The following is a description of a gene set: from publication Wei G, Wei L, Zhu J, Zang C, Hu-Li J, Yao Z, Cui K, Kanno Y, Roh TY, Watford WT, Schones DE, Peng W, Sun HW, Paul WE, O'Shea JJ, Zhao K (PMID 19144320) Multipotential naïve CD4+ T cells differentiate into distinct lineages including T helper 1 (Th1), Th2, Th17, and inducible T regulatory (iTreg) cells. The remarkable diversity of CD4+ T cells begs the question whether the observed changes reflect terminal differentiation with heritable epigenetic modifications or plasticity in T cell responses. We generated genome-wide histone H3 lysine 4 (H3K4) and lysine 27 (H3K27) trimethylation maps in naïve, Th1, Th2, Th17, iTreg, and natural (n)Treg cells. We found that although modifications of signature cytokine genes (Ifng, Il4, and Il17) partially conform to the expectation of lineage commitment, critical transcription factors such as Tbx21 exhibit a broad spectrum of epigenetic states, consistent with our demonstration of T-bet and IFN-gamma induction in nTreg cells. Our data suggest an epigenetic mechanism underlying the specificity and plasticity of effector and regulatory T cells and also provide a framework for understanding complexity of CD4+ T helper cell differentiation. species: Homo sapiens Genes up-regulated in comparison of Th2cells versus induced regulatory T cell (Treg). Human Gene Set: GSE14308_TH2_VS_INDUCED_TREG_UP, and this is the list of marker genes: PRSS22, MAGI2, KLF10, GTSF1, IDS, GKAP1, ACAP3 (NCBI Gene Id 80855), SLC36A1, IFT27, BCAR3, TPP1, ARPC1A, TAF13 (TATA-box binding protein associated factor 13), PDLIM2, CDKL2, DARS1, RTL8B, PURA, ZCCHC13, PANK2, RPS26, MTPN, DGUOK, ECI2, RGS11, OSBPL3, B2M, IRS2, CLK4, MSI2, INPPL1, ARAP3, GALNT18, ARPC2, MKRN1, EIF5, KATNBL1 (katanin regulatory subunit B1 like 1), CEP250, AIP, LEPROTL1, DKKL1, GMPPA, MFSD8, AGA (NCBI Gene Id 175), LRP6, VILL, PHLDA3, ORC4, TBPL1, FKBP8, PHF1, RELCH, STAP1, NAB1, MYH11, TIA1, OLA1, FAM13B, YME1L1, BET1, ZC2HC1A, GYG1, GPRIN3, PRMT9, KIZ (NCBI Gene Id 57166), SPMAP1, HCN2, CDC42BPG, COMMD6, PHF21B, HK1, MASTL, ASPM, P2RX6, VPS37C, ALDH4A1, BIK, MEGF9, EXOC4, PLS3, TAFAZZIN (NCBI Gene Id 6901), H2AC25, SYNE1, NUDT6, PCSK1, CCSER2, RAD17, MED7, MAP4K4, FHIP2B, RPS6KB1 (ribosomal protein S6 kinase B1), RPL14, CCDC92, JAK1, IRAK2, SLC12A6, SLC52A3, OLFM1, NAPSA, SPNS3, TRAPPC6B, CAV2, PLCL2, GZF1, OXSM, MDM2, STAM2, SH3BGRL, GOSR1, ITK, PIK3C3, DDX5, FOXO3, DAAM1 (dishevelled associated activator of morphogenesis 1), WRAP73, PLA2G12A, SRA1, NR1H2, OSGEP, SIPA1L1, SECISBP2L, DNAAF9, YOD1, SNX9, CEP135, SMPD2, SYNJ2BP, HS6ST1, EPS8, AKR1B15, SUMF1, MRPL35, RIC8A, WBP4, DDX6, SP6, CCL24, PTPRCAP, NUDT7, INHBA, PLCL1 (NCBI Gene Id 5334), FTL, VPS4B, SYNJ1, IMPACT, GOLGA7, SURF1, ATXN1L, TOX3, TMEM203, BTBD8, WDR26, CFAP68, SCYL1, AKAP7, PPP2R5E, ERAP1, PXK, APOBEC4, TRIM5, RNF167, NEK7, CHD7, SPATA1, ZNF414, SPRY2, RBM22, LRIF1, PBX3, SRPK1, PTTG1, STX7, NCEH1, SRXN1, CISH, AMN1, EXOC5 (NCBI Gene Id 29024), ITFG1, USP15, UNC45A, TMEM161B, RPE, ESRRA, PNPLA7, PPP6R3, AGPAT2, UNC13A, PCGF1, CCDC39 (coiled-coil domain 39 molecular ruler complex subunit), C1orf53, B4GALNT4, STAG1, ERCC5, C12orf57, SCAMP2, ZNF260, NCBP2AS2, FBXW4